The following is a description of a gene set: Absent eyelids. Human Gene Set: HP_ABLEPHARON Ablepharon species: Homo sapiens, and this is the list of marker genes: TWIST2, PSAT1, PHGDH, RIPK4, POLR1A (NCBI Gene Id 90784)